Given this list of marker genes SLC29A2, SLC28A3, SLC23A3, SLC28A1, VDAC3, SLC29A1, SLC29A3, SLC25A5, SLC28A2, SLC23A1, SLC25A4, AQP9, SLC43A3, here is a description of the gene set: Human Gene Set: GOBP_NUCLEOBASE_TRANSPORT The directed movement of a nucleobase, any nitrogenous base that is a constituent of a nucleoside, nucleotide, or nucleic acid, into, out of or within a cell, or between cells, by means of some agent such as a transporter or pore. studied in species Homo sapiens